Given this list of marker genes NDUFC2, NDUFB2, NDUFB9, NDUFA4, SCO1, ATP5F1C, NDUFS4, UQCRH, COX7B, SLC25A6, ATP5MG, ATP5ME, MT-ND2, NDUFAB1, ATP5F1A, ATP5F1B, NDUFA8, COX17, ATP5IF1, COX7A1, SDHB, ATP5MC3, NDUFS8, NDUFA3, UQCRFS1, NDUFB6, SDHD, MT-ND1, NDUFA2, NDUFB1, ATP5MF, NDUFS2, NDUFA12, NDUFB3, NDUFS3, ATP5PO, NDUFB8, MT-CO1, UCP2 (uncoupling protein 2), UQCR11, NDUFA10, SURF1, MT-ND3, COX8A, COX7C, UQCR10, COX6A1, NDUFC1, NDUFS7, UQCRC1, NDUFA6, MT-ND4L, NDUFS6, NDUFA7, UCP1, UCP3, SLC25A5, SLC25A4, COX11, NDUFV2, NDUFA9, ATP5MC1, ATP5F1D, MT-ND6, MT-ATP8, MT-ND4, ATP5MC2, UQCRC2, UQCRQ, SDHA, MT-ATP6, MT-CO2, COX7A2L, NDUFS1, NDUFB10, NDUFV3, COX4I1, UQCRB, NDUFV1, NDUFB5, MT-CO3, SLC25A27, COX6B1 (NCBI Gene Id 1340), NDUFS5, COX15, DMAC2L, COX5A, ATP5PF, ATP5PB, COX7A2, NDUFB7, MT-ND5, SDHC, COX5B, COX6A2, NDUFA1, NDUFA11, MT-CYB, NDUFA5, SLC25A14, ATP5F1E, ATP5PD, NDUFA13, COX6C, NDUFB4, here is a description of the gene set: Human Gene Set: WP_ELECTRON_TRANSPORT_CHAIN_OXPHOS_SYSTEM_IN_MITOCHONDRIA species: Homo sapiens Electron transport chain: OXPHOS system in mitochondria